Given this list of marker genes PLPPR4, RAB28, TFAM, SPRTN (NCBI Gene Id 83932), QDPR, TM6SF1, ATP2A2, TASOR, TSHZ1, DNER, SEC11A, ARID4A, here is a description of the gene set: from publication Chen Y, Wang X (PMID 31504780) Genes predicted to be targets of miRBase v22 microRNA hsa-miR-4798-3p in miRDB v6.0 with MirTarget v4 prediction scores > 80 (high confidence targets). species: Homo sapiens Human Gene Set: MIR4798_3P